Given this list of marker genes CCDC124, TRIOBP, NEXMIF, VPS4B, SEPTIN1, PKN2, GNAI1, JTB, PKN1, YPEL5, TACC1, MBD5, EXOC6, CEP44, UVRAG, RNF8, FLCN, KIF13A, FAM50B, EXOC7, NEK2, MICAL3, IL16, MTCL2 (microtubule crosslinking factor 2), PITPNM1, GDI1, USP8, MICAL1 (microtubule associated monooxygenase, calponin and LIM domain containing 1), KATNA1, ASPM, MTCL1, MAP7D2, RACGAP1, TXNDC9, HSPA5, SLC2A1, KIF4A, ZNF330, SVIL, PDXP, DEFA5, CPEB3, LYRM1, FIRRM, CENPE, CENPC, RAB11FIP4, PRC1, RAB11FIP3, IST1, LATS1, VPS37B (VPS37B subunit of ESCRT-I), CHMP2A, TBCK, PSRC1, STK17B, SSH1, KATNB1, SAFB, MPLKIP, CHMP3, EML3, SH3GLB1, MAK, SPAG5, KEAP1, TTC23L, ERH, CEP55, CHMP4B, CLIC4, C9orf72, TEX14, CHMP5, GNL3, SHCBP1, LZTS2, GEM, RALB, URB2, ARL8B, DDX11, EXOC1, NUDC, RAP2A, AURKA, PTCH1, SEPTIN7, PIN1, GNAI2, SEPTIN6, INCENP, OR2A4, RAB8A, CHMP4C, CDK1, ENTR1, KLHL9, DCDC1, NUP62, MARK4, CHMP2B, CTDP1, TTC19, CTNND1, CENPF, USP3, CRMP1, CDCA8, AGBL5, BIRC6, RAN, VPS4A, ALKBH4, EXOC5, CHMP7, RCC2, CENPV, CNTRL, MAPRE3, RASGEF1B (NCBI Gene Id 153020), LUZP1, KIF14, DCTN3, CHMP4BP1, C6orf89, DTNBP1, KIF20B, CYLD, KIF23, SIRT2, RDX, ZFYVE26, SEPTIN12 (septin 12), CCDC69, PLK1, GNAI3, DAPK3, ARL2BP, ANKRD54 (ankyrin repeat domain 54), RHOA, ANLN, ANXA2, KIF20A, RALA, TSG101, POLDIP2, PPP1CC, ARF6, EML4, CAPG, MYH10 (myosin heavy chain 10), ATXN10, CIAO2B, TTC28, RAD21, TTLL12, FOXL2, EXOC4, CHMP1B, HSP90B1, ECT2, BCL3, TOPORS, AURKB, CHMP1A, CEP126, APC2, SPART, DNM2, ABRAXAS2, RACK1, AGAP2, EXOC3, HEPACAM2, TRAPPC14 (trafficking protein particle complex subunit 14), ANXA11, AURKC, MITD1, CCDC146, WIZ, CCDC66, ARL8A, NAT10, PKP4, KIF3B, MAP10, KLHDC8B, SPAST, ANKRD45, PDCD6IP, SCCPDH (saccharopine dehydrogenase (putative)), CELF2, BIRC5, HNRNPU, SEPTIN2, MAP7D1, CHMP4A, ZFYVE19, EXOC2, PIK3C3, USP50, CHMP6, SSNA1, ARL3, CDC42, IQGAP1, PIK3CB, KATNBL1, here is a description of the gene set: studied in species Homo sapiens Human Gene Set: GOCC_MIDBODY A thin cytoplasmic bridge formed between daughter cells at the end of cytokinesis. The midbody forms where the contractile ring constricts, and may persist for some time before finally breaking to complete cytokinesis.